Given this list of marker genes FBLN1, EPB41L5, STK4, TNFRSF12A, FN1, here is a description of the gene set: The formation of adhesions that stabilize protrusions at the leading edge of a migrating cell; involves integrin activation, clustering, and the recruitment of structural and signaling components to nascent adhesions. species: Homo sapiens Human Gene Set: GOBP_SUBSTRATE_DEPENDENT_CELL_MIGRATION_CELL_ATTACHMENT_TO_SUBSTRATE